The following is a description of a gene set: studied in species Mus musculus Cytokines mediate cell-cell communication in the immune system and represent important therapeutic targets. A myriad of studies have highlighted their central role in immune function, yet we lack a global view of the cellular responses of each immune cell type to each cytokine. To address this gap, the authors created the Immune Dictionary, a compendium of single-cell transcriptomic profiles of more than 17 immune cell types in response to each of 86 cytokines (>1,400 cytokine-cell type combinations) in mouse lymph nodes in vivo. A cytokine-centric view of the dictionary revealed that most cytokines induce highly cell-type-specific responses. For example, the inflammatory cytokine interleukin-1β induces distinct gene programmes in almost every cell type. A cell-type-centric view of the dictionary identified more than 66 cytokine-driven cellular polarization states across immune cell types, including previously uncharacterized states such as an interleukin-18-induced polyfunctional natural killer cell state. Genes negatively differentially expressed in cell type: pDC (plasmacytoid dendritic cell) upon treatment with cytokine: LIF in mouse lymph nodes in vivo. from publication Cui A, Huang T, Li S, Ma A, Pérez JL, Sander C, Keskin DB, Wu CJ, Fraenkel E, Hacohen N (PMID 38057668) Mouse Gene Set: CUI_PDC_LIF_RESPONSE_DN, and this is the list of marker genes: Khk, R3hdm4, Eif3e, Btg2, Ypel3, Ramp1, Cmah (NCBI Gene Id 12763)